Given this list of marker genes Slc15a4, Hmgb1, Cd300ld3, Ptpn22, Rsad2, Treml4, Zdhhc3, Tlr9, Rtn4, here is a description of the gene set: studied in species Mus musculus Mouse Gene Set: GOBP_POSITIVE_REGULATION_OF_TOLL_LIKE_RECEPTOR_9_SIGNALING_PATHWAY Any process that activates or increases the frequency, rate, or extent of toll-like receptor 9 signaling pathway.